Given this list of marker genes SEMA3E, PXK, PAX6, ARX, TMEM47, THSD7A, FGFR1, TM4SF4, SLITRK6, PEG10, TMEM176B, PPY, S100A10, AKAP12, FXYD6-FXYD2, STMN2, BMERB1, CALB1, MEIS2, CHN2, CPB1, DPYSL3, INPP5F, SCGB2A1, SERTM1, AMOTL1, GCNT3, ABCC9, CARTPT, ID1, CHRM3, GC, SPINK1, TXNIP (thioredoxin interacting protein), ID4, ID2, AQP3, SLC4A4, FXYD2, ETV1, SPOCK1, ABCB1, SCG2, SLC6A4, PTP4A3, here is a description of the gene set: studied in species Homo sapiens Single cell RNAseq data from human pancreatic islets was downloaded from 7 previously published datasets. Pairwise differential expression was calculated between all islet cell types in each dataset, and results were integrated to compose a core list of ID genes for each cell types, organised primarily on the number of analyses a gene was detected in. A machine-learning based approach was used to threshold which genes were included in the final ID geneses, and these genesets were then cross validated in three independent datasets to demonstrate they outperformed previously published lists of ID genes. from publication van Gurp L, Fodoulian L, Oropeza D, Furuyama K, Bru-Tari E, Vu AN, Kaddis JS, Rodríguez I, Thorel F, Herrera PL (PMID 35440614) Human Gene Set: VANGURP_PANCREATIC_GAMMA_CELL Transcriptomic signature geneset for human pancreatic gamma cells derived from meta-analyzing multiple single cell RNAseq datasets